Given this list of marker genes Ascl1, Dlx2, Sall1 (spalt like transcription factor 1), Gsx2, Dlx1, Lhx6, Rac1, Arx, Nkx2-1, Bcl11b, Shank3, Inhba, Fezf2, Rac3, Cntn2, Ulk4, Helt, Drd1, Drd2, Prdm13, Bhlhe22, Gata2, Zswim6, Tlx3, here is a description of the gene set: studied in species Mus musculus The process in which a neuroblast acquires the specialized structural and functional features of a GABAergic neuron. Mouse Gene Set: GOBP_GABAERGIC_NEURON_DIFFERENTIATION